The following is a description of a gene set: RNA Polymerase I Transcription Initiation Human Gene Set: REACTOME_RNA_POLYMERASE_I_TRANSCRIPTION_INITIATION species: Homo sapiens, and this is the list of marker genes: ERCC6, TAF1C, CDK7, GTF2H1, ERCC3, EHMT2, GATAD2B, POLR1A, MNAT1, TAF1B, POLR2K, GTF2H2, MBD3, MTA1, TAF1D, POLR1B, HDAC2, POLR2E, UBTF (NCBI Gene Id 7343), ERCC2, MTA3, KAT2B, MTA2, CHD4, POLR1G, KAT2A, POLR1E, GATAD2A, TTF1, CHD3, GTF2H4, TBP, TAF1A, CCNH, GTF2H5, HDAC1, POLR2L, RBBP7, RBBP4, POLR2H, RRN3, POLR1D, GTF2H3, POLR2F, POLR1H, POLR1F, POLR1C